The following is a description of a gene set: Human Gene Set: REACTOME_P75NTR_RECRUITS_SIGNALLING_COMPLEXES species: Homo sapiens p75NTR recruits signalling complexes, and this is the list of marker genes: UBC, NGF, NGFR, MYD88, RIPK2 (receptor interacting serine/threonine kinase 2), TRAF6, IKBKB, UBA52 (ubiquitin A-52 residue ribosomal protein fusion product 1), UBB, PRKCI (protein kinase C iota), RPS27A, IRAK1, SQSTM1